The following is a description of a gene set: Any process that results in a change in state or activity of a cell or an organism (in terms of movement, secretion, enzyme production, gene expression, etc.) as a result of an abiotic (not derived from living organisms) stimulus. studied in species Mus musculus Mouse Gene Set: GOBP_RESPONSE_TO_ABIOTIC_STIMULUS, and this is the list of marker genes: Cetn1, Mir705, Sik1, Slc7a11, Ifi208, Triap1, Chek1, Prkcd, Ripor2, Trex1, Mir133a-1, Insrr, Ankrd23, Mir223, Best1, Wrn, Ada, Stx1a, Egfr, Slc29a1, Rock2 (NCBI Gene Id 77848), Fgf2, Chi3l1, Akt2, Cacna1e, Neurod2, Mir26a-2, Lonp1, Mir665, Mtpn (NCBI Gene Id 319218), Bhlhe40, Carlr, Kcnj3, Hsf3, Rnf34, Casp2, Ece1, Apobec1, Vegfc, Mfap4, Zfp36l1, Fndc1, Kat5, Atg7, Mir31, Gucy2f, Trpv4, Pkd1l3 (polycystic kidney disease 1 like 3), Rbx1-ps, Inip, Nedd4l, Agtr1a, Kras, Scn1a, H2ax, Ajuba, Hsd11b2, Pdcd6, Nfe2l1, Bcl3, Cers1, Acer1, Fzd4, Xrcc5, Rbm4, Adm, Nfatc4, Tsc22d2, Lrit1, Ddhd2, Tert, Gip, Pten, Stc2, Chrd (NCBI Gene Id 12667), Slc52a3, Trpm2, Egln2, Ptprq, Slc39a12, Opn1sw, Slc2a4, Hsbp1, Arrb2, Ucn3, Mir29b-2, Mir511, Ghrl, Nsmce3, Angpt4, Angpt2, Chrna5, Strbp, Ngb, Palm (NCBI Gene Id 18483), Cacnb4, Mir16-1, Usp1, Grin1, Il12a, Cat, Cryab, Lcn10, Col6a2, Nlrp3, Gpr151, Nos1, Rhno1, Smad4, Creb1 (NCBI Gene Id 98624), Polk, Itpr1, Asic2, Eif2b2, Kmo, Ang, Dram1, Igfbp2, Parp1, Mkks (McKusick-Kaufman syndrome), Star, Pold1, Kcnj8, Pld2, Mtor, Acaa2, Nfkbia, Epas1, Tmc1, Mdm2, Dnaja1, Xylt1, Eno1, Bag3, Aen, Hilpda, Tspo, Mir574, Il12b, Ccr2, Clcn2, Vhl, Meis2, Higd1a, Usp15, Rtn4, Ccng1, Chrna4, Scel, Asns, Eif4ebp1 (eukaryotic translation initiation factor 4E binding protein 1), Lrp2, Aqp5, Strc, Fam162a, Ihh, Pgk1, Ager, Loxl2, Hp1bp3, Pnp, Spidr, Rad23b, Ttn, Trh, Stk39, Ddah1, Mapk3, Fyn, Srf, Nucks1, Myod1, Vps13a, Sdhd (NCBI Gene Id 97524), Ddb1, Mir668, Tek, Adam2, Adam8, Cysltr1 (cysteinyl leukotriene receptor 1), Pde2a, mt-Co1, Kcnj11, Slco1b2, Grm8, Ddx3x, Bak1, Adam17, Cdc25a, Mapt, Sst, Mir711, Nek1, Ntsr1, Rdh13, Scx, Gucy1b2, Fcor, Txnip, Sod1, Capn2, Hspb6, Kdm4d, Hsp90aa1, Ddias, Large1, Rad51, Mir154, Sod3, Nop53 (NOP53 ribosome biogenesis factor), mt-Nd5, Tnks1bp1, Alas2 (aminolevulinic acid synthase 2, erythroid), P4hb, Nts, Atp1b1, Per2, Hk2, Nlk, Ephb1, Stra6, Tacr2, Grin2b, Mir301, Atp2b4, Gpr4, Krt5, Appl2, Disc1, Prl8a2, Pbk, Fzd3, Plin1, Mir15a, mt-Nd1, Mir148b, Ak4, Scrn3, Kcnma1, Ext1, Mlc1, Pik3ca, Pcsk1n, Tcim, Uts2, Fbxo4, Tac1, Id2, Nrxn2, mt-Atp6, Ercc6, Csrp3, Crb1, Ei24, Camk2d, Il3, Smad3, Tm9sf4, Irf1, Il1r1, Ifi214, B4galt2, Cdkn1b, Penk, Tuba1a, Gjb6, Krt14, Mc1r, Tifab (TRAF-interacting protein with forkhead-associated domain, family member B), P2ry1, Il18, Lrrn4, Map1b, Angptl4, Ankrd1, Rrh, Eif2s1, Lrit3, Cr1l, Mir222, Cngb1, Slc27a1, Pkd1l1, Slc12a6, Ltbr, Adora1, mt-Nd3, Prkdc, Brca1, Mirlet7b, Pkn1, Mir133b, Daxx, F11r, Ndufs2, Pde6c, Nrg1, Mme, Kcna1, Ppp1cb, Grb2, Tulp1, Cacna1c, Ifi206, Cd24a, Rhbdd1, Mdk, Serpinb6c, Rcvrn, Pdcd10, Map4k3, Ybx3, Aurkb, Gnb1, Hspa8, Tmbim6, Micu1, Clk2, Atp1a1, Tipin, Flt1, Tafa2, Umod, Rad9b (NCBI Gene Id 320366), Scn2a, Bbc3, Eif2b5, Rad51ap1, Pcare, Scn9a, Yy1, Mir1895, Mmp1b, Hras, Mapk10, Nf1, Rbm4b, Uimc1, Etv1, Htr2a, Foxo3, Ercc1, Tmem87a, Gucy1a2, Crtc1, Eya1, Cryaa, Ubqln1, Cxcl12, Babam2, Vcp, Mir30e, Ace, Foxb1, Gsn, Cyp2r1, Cd40, Dynlrb1, Ivl, Xrcc1, Map3k20, Mgarp, Gnat1, Ptgs2, Tacc3, Ercc8, Hus1, Tsc1, Col3a1, Brcc3dc, Atp1a3, Hmgcr, Chp1, Ric8a, Lrrc8d, Birc2, Wtip, Stat3, Cdkn2d, Rho, Slc25a27, Lrrc8e, Mirlet7e, Fbxl3, Rpe65, Cxcl2, Dclre1c, Pparg, Bnip3, Tlr3, Slitrk6, Agap3, Atp6v0a2 (ATPase, H+ transporting, lysosomal V0 subunit A2), Eif2b3, Anxa7, Tgfb1, Vegfa, Cacnb3 (calcium channel, voltage-dependent, beta 3 subunit), Lif, Higd1c, Shank3, Ccdc115, Ube4b, Mmp9, Dct, Ift20, Dhx36, Sost, Foxp2, Brca2, Npepps, Txn2, Sdf4, Efhd1, Mir376a, Trpa1 (transient receptor potential cation channel, subfamily A, member 1), Agtrap, Acadm, Gad2, Aqp3, Mir204, Dcdc2a, Bdkrb1, Wnt11, Tfec, Atoh7, Lrrc8c, Plekhn1, Abcc9, Ang4, Slu7, Slc1a1, Ticrr, Mstn, Pmp22, Ero1a, Pkdrej, Txn1 (thioredoxin 1), Cpeb1, Cry2, Mir199a-2, Endog, Itga2, Tlr7, Adss2, Mir30b, Reep6, Ube2b, Hspb2, Mir762, Comt, Kmt2a, Ifi203, Dnaja2, Nlgn3, Kdr, Gpsm2, Psip1, Scn11a, mt-Cytb, Col11a1, Gata6, Slc8a1, Rpl26, Mir7b, Ints7, Lpar1, Oxtr, Itgb6, Ap1s2, Xrcc4, Ddit4, Nedd4, Guca1a, Myc, Bmp6, Nhej1, Rab11fip5, Mir140, Mir483, Ptpn1, Ctnnb1, Pak1, Mir10a, Prkg2, Per3, Prl4a1, Rbx1, Mir9-2, Ptgis, Atp6v1a, Usp2, Eif2b4, Mir92b, Nppb, Myo6, Ercc2 (excision repair cross-complementing rodent repair deficiency, complementation group 2), Sirt1, Abcb1a (ATP-binding cassette, sub-family B member 1A), Ang2, Col6a1, mt-Co2, Mir1192, Gja3 (gap junction protein, alpha 3), Adrb1, Pola1, Ppp1r1b, Mir499, Nfkb1, Usf1, Aqp2, Drd3, App, Mir379, Zfp976, Relb, Htr7, Suv39h1, Acvr2a, Crnn, Uaca, Opn5, Acot11, Kcnq1, Tlr8, Xrra1, Grk1, Ckm, Rad54l, Rgcc, Hmox1, Tbl2, Hoxa1, Mir127, Ccnd1, Pclaf, Nr4a2, Mir132, Ttpa (NCBI Gene Id 50500), Sumo1, Vasn, Slc4a10, Kcnk9, Nr2f6, Ppid, Noc2l, Trp53bp1, Hnmt, Kcnd2, Gnb5, Brcc3, Tsc22d3, Blm, Fancg, Calca, Atxn3, Hspa2, Sox2, Ccna2, Chrna9, Ccdc66, Kcnj2, Pln, Ndrg4, Hpn, Mir207, Rela, Cntnap2, Atp6v0d1, Mief1, Polr2a, Cops9, Polh, Hnrnpd, Acot2, Atxn1, Ednra, Tnfrsf11a, Zbtb1, Pold3, Hikeshi, Mmp3, Map2k1, Rgs14, Th, Ucn, Chrna10, Slc8a3, Fabp1, Src (Rous sarcoma oncogene), Sipa1, Hyal1, Mir34a, Sox4, Rest, Mir199a-1, Kdm1a, Tsc2, Drgx, Bcl2l1, Casp9, Lck, Mir30d, Prmt2, Kcnq3, Mir194-2, Serpinb6a, Metrnl, Mir874, Opn1mw, Vac14, Grin2d, Mir3092, Xbp1, Tlr4, Rad23a, Ryr2, Lep, Sirt6, Ascl1 (NCBI Gene Id 17172), D7Ertd443e, Pgf, Nog, Fbxw7, Egln1, Rbbp7, Hyal3 (NCBI Gene Id 235600), Ang6, Thra, Trpv2 (transient receptor potential cation channel, subfamily V, member 2), Hsp90ab1, Rad21, Ifi209, Slc7a5, Hsp90b1, Sfrp1, Mmp1a, H2ac25, Casp1, Cbl, Mmp24, Vldlr, Ang5, Mbd2, Lrrc8a, Ep300, Serpine2, Htra2, Crebbp (CREB binding protein), Per1, Nrxn1, Myof, AU040320 (NCBI Gene Id 100317), Pml, Pdcl3, Kcnc2, Trp53i13, Wdr47, Arpp21, Ercc3, Cln3, Mt3, Mir100, Col1a1, Ifi213, Scnn1g, Slc12a2, Cdk2, Prph2, Ccl2, Rad18 (RAD18 E3 ubiquitin protein ligase), Limd1, Nppc, Nrf1 (nuclear respiratory factor 1), Gpr65, Akap12, Mir107, Kcnq2, Ccl7, Gba1, Slc4a11, Ywhae, Jup, Cav1, Arrb1, Calb1, Pck1, Myo15a, Zfp516, Aqp1, Ptprk, Dnajc3, Marveld3, Piezo2, Smpd1, Ddb2, Casr, P2rx2, Mir3473c, Kars1, Mir26a-1, Hif1a, Hyou1, Mndal, Ptprc, Tmc2, Lct, Tmem135, Mapk13, Scara5, Casq1, Aldh18a1, Rab3a, Usp28, Il1a, Cyp1a1, Chuk, Nox1 (NCBI Gene Id 278150), Letm1, Plau, Gpx1, Fmn2, Mir221, Mir300, Sirt4, Ndnf, Calr, Rgr, Syngap1, Hsf1, Pawr, Bmf (BCL2 modifying factor), Prickle2, Plod1, Itgb3, Clcn6 (NCBI Gene Id 26372), Itpr2, Eif2ak4, Agtr1b, Elane, Tmem199, Rps6kb1, Atp2b2, Mbd4, Tnf, Myocd, Mir142, Fbxl21, Inhba (inhibin beta-A), Capn3, Abl2, Chek2, Nfatc3, Oxsr1, Pcna, Rgs9, Nipbl, Bace1, Tmem150c (transmembrane protein 150C), F7 (NCBI Gene Id 14068), Fech, Nlrp1b, Agt, Dio3, Pick1, Myog, Fundc1, Mir365-1, Tgfb2, Pjvk, Grm6, Ercc4, Eif2ak3, Nfat5, Pou4f2, Sod2, Elk1, Chrna7, Hif3a, Lhfpl5, Grin2a, Dtl, Cldn3, Smpd2, Zmpste24, Rad54b, Tnfrsf1a, Tanc1, Cry1 (cryptochrome circadian regulator 1), Xrcc6, Mir9-1, Mir20b, Foxo1, Fosl2, Clock, Oprd1, Akt1, Lxn, Mst1, Hspd1, Pink1, Cbfa2t3, Slc38a2, Reg1, St8sia1, Plk3, Kcnk18, Rnf8, Fosb, Casp7, Igf1, Rgs9bp, Cds2, Hyal2, Abat, Cbs, Kcnc1, Thbs1, Fas, Vegfd, Nos2, Mir199b, Mir410, Ptprd (NCBI Gene Id 71786), Arnt2, Gpr68, Adam15, Mir133a-2, Bax, Prickle1, Irak1, Scnn1a, Cul4a, Cnn2, Sema5b, Fbxo32, Pnpla2, Mir691, Atm, Sema5a, Mir21a, Edn1, Swi5, Cav3 (caveolin 3), Mir434, Tcap, Mir451a, Rasa3, Nkx3-1, Pierce1, Atf2, Hvcn1, Tlk2, Hmgn1, Cybb, Mir125b-1, Pkd1l2, Phf24 (PHD finger protein 24), Lipe, Zfas1 (NCBI Gene Id 68949), Ppp1ca, Slc2a8, Bdkrb2, Lta, Cep250, Plat, Sts, Scn2b, Phb2 (prohibitin 2), Lncbate10, Ptafr, Pirt, Ado, Gnat2, Itgb1, Smc1a, Deaf1, Ankrd2, Tspyl5, Nscme3l, Eif2b1, Sun1, Htt, Saxo1, Cdk5 (cyclin dependent kinase 5), Grm1, Acadvl, Lrrc25, Ano3, Abhd12, Paxip1, Mrnip, Asic1, Map2k7, Notch1 (notch 1), Pianp, Rhob, Slc4a1, Piezo1, Brsk1, Pcp2, Pde8b, Clpb, Crhr1 (NCBI Gene Id 12921), Tmem120a, Prkaa1 (protein kinase, AMP-activated, alpha 1 catalytic subunit), Gpld1, Pygm, Pde1b, Neto1, Mill1, Xrcc2, Rac1, Mir208a, Arnt, Cfh, Slc6a4, Ube2a, Slc12a5, Cited2, Trp53, Rbp4, Ryr1, Serpinb6b, Prap1, Nfe2l2, Trem2, Map3k14, Mir365-2, Ndufs4, Mir101b, Eef2k, Dbh, Cck, Dmd, Tg, Nabp2, Polb, Fbp1, Ptch1, Pdk1, Cxcr4, Gngt1, Serpinf1, Ano1, Gata4, Ucp1, Sirt2, Mkx, Bnip3l, Map1lc3a, Mir327, Mir103-1, Gnat3, Ptger4, Vgf, Rab11b, Ect2, Ifi207 (interferon activated gene 207), Mta1, Lipa, Mir26b, Slc38a3, Dpm1, Brd1, Stac, Actr5, Wdr83, Parp2, Scnn1b, Gria1, Stc1, Opn4, Ptpn11, Fancd2 (Fanconi anemia, complementation group D2), Rom1, Abcg5, Trpv1, Wnk3, Drd1, Nlrp1a, Slc9a1, Gpi1, Gdf5, Tmem109, Xpa, Abcb1b, Mirlet7d, Akr1b1, Pdzd7, Il1b, Map7, Chchd2-ps (NCBI Gene Id 433806), Rad1, Usp53 (NCBI Gene Id 99526), Cdkn2a, D1Pas1 (DNA segment, Chr 1, Pasteur Institute 1), Scn7a, Ngfr, Hspa1a, Rbm3, Pmaip1, Ndrg1, Tank, Eno1b, Pde6d, Hpcal4, Mir9-3, Musk, Frmpd1, Brat1, Nsmf, Chrnb2, Acvrl1, Got1, Gfi1, Tjp1, Cpeb4, Grik2, Otop1 (otopetrin 1), Crip1, Pin1, Net1 (NCBI Gene Id 78563), Epha4, Timp1, Ercc5, Gpr88, Mir335, Prdm12, Atp8a2, Fos, Raf1, Mir491, Kcnk3, Prkaca (NCBI Gene Id 18747), Myd88, Mmp2, Mettl3, Pax2, Gpr52, Ppp1cc, Actb, Ninj1, Ckap5, Rnf4, Synpo, Tac4 (tachykinin 4), Hpca, Slc1a3, Map2k4, Eya3, Eng, Fignl1, Kcnk2, Hrh2, Serpinb6d, Ints3, Dnaja4 (NCBI Gene Id 80397), Atp1a2, Abcc8, Acta1, Bltp1, Gja1, Nps, Adgrv1, Arhgdia, Pin1rt1, Gucy1b1, Nr4a1, Lmna, Xpc, Dhx9, Pdlim1, Dnmt3a, Dnajb1, Irx6, Tacr1, Rora, Pkd2l2, Npm1, Tfrc, Brip1, Uvssa, Plac8, H2aj, Mknk1, mt-Nd4, Mir5621, Fosl1, Cyfip1, Bcl2, Drd5, Braf, Nabp1, Ireb2, Ttr, Pik3r1, Mir143, Scap (SREBF chaperone), Hspa1b (NCBI Gene Id 15511), Gja10, Ctns, Stk11, Rad9a, Adrb2, Sct, Krt8, Habp4, Kcne1, Bmp2, Tgfb3, Ppara, Abraxas1, D130043K22Rik, Msh2, Aipl1, Rcsd1, Mir137, Mir760, Gypa, Sox9, Rptor, Sde2, Bbs10, Trpm1, Adsl, Trp53inp1, Hspb1, Mtch2, Kit, Mcrip2, Slc2a1, Tsc22d4, Slc26a5, Cacna2d4, Gh, Oxt, Ciao3, Sgk1, Topbp1, Mir146, Rev1, Trpv3, Lyn, Il33, Cop1, Ptk2b, Rnf170, Mapk9, Cd14, Nos3, Cacna1f (calcium channel, voltage-dependent, alpha 1F subunit), Pcdh15, P2rx5, Twist1, Ruvbl2, Clcn7, Pdpk1, Atat1, Scn10a, Suv39h2, Hsbp1l1, Mir15b, Hmgcs2, Babam1 (BRISC and BRCA1 A complex member 1), Atp6ap1, Dpp4, Jun, Plec, Tnfsf14, Cidea, Slc24a4, Ccar2, Mir99a, Apaf1, Psph (phosphoserine phosphatase), Atf4, Adipoq, Mag, Pias1, Mcoln1, Mapk14, Ndp (NCBI Gene Id 236713), Mir155, Kcna5, Cdkn1a, Lgmn, Cygb, Tyr, Slc1a2, Vegfb, Wnk1, Bcl10, Tigar, Mir126a, Yap1, Mir150, Mlst8, Dnaja3, Ifi203-ps, Mir652, Cysltr2, Btg2, Pik3cb, Cpt1b, Cradd, Gucy1a1, Nol3 (nucleolar protein 3 (apoptosis repressor with CARD domain), NCBI Gene Id 78688), Pkd2, Casp3, Gap43, Bad, Bard1, Mir29b-1, Gsk3b, Asic3, Dnm1l, Zeb2, Mecp2, Cabp4, Cd38, Mir495, Col6a3, Dcun1d3, Clca1, Rpgr, Rag1, Nptn, Scfd1, Mir214, Egr1, Ogt, Mir146b, Egln3, Mir16-2, Guca1b, Mpo, Usp19, Eef1d, Ascl2, Tnc, Mapk11, Ciita, Ier5, N4bp1, Pdk3, Bmyc, Ucp2, Nox3, Abraxas2, Trim32, Gpr31b, Rfwd3, Pkd2l1, Tfam, Chchd2, Trpm8, Ucp3, Pam, Adra1b, Dag1, Car9, Commd1, Idua, Tmem161a (transmembrane protein 161A), Mir92-2, Serpinb6e, Sfrp2, Gclc, Thbd, Fgf1 (NCBI Gene Id 14164), Whrn, Drd2, Becn1, Nono, Arsa, Gna11, Ccnd2, Hrh1, P2rx7, Gadd45a, Cpeb2, Kcnk4, Atp6v1g1, Acadl, Kdm6a, Mmp14, Camk2g (NCBI Gene Id 218813), Mir106a, Aanat, Ddr2, Alkbh5, Poli, Mir29c, Lig4, Ino80, B3gat1, Gata3, Rpain, Osm, Rrm1, Adrb3, Trp53bp2, Rnf168, Slc25a23, Ptn (pleiotrophin), Ces1d, Fadd, Agrp, Aifm1, Arsb, Pde6b, Alad, Gtf2h5, Nqo1, Epo, Neurog1, Ogg1, Mirlet7g, Pycard, Snai2, Mir695, P2rx3, Mir497, Ppard, Cdh8, Lrp11, Mir17, Zzef1, Mapk8, Map3k4, Atr (NCBI Gene Id 382093), Abca7, Mb, Aldh3a1, Sprtn, Dysf, Mir10b, Gpr179, Rwdd3, Cpt1a, Rp1, Zranb3, Opn3, Hmox2, Ttc36, Kcnk1, Ntrk1, Tpr, Msh6, Cirbp, Ro60, Prkce, Trim63, Ctss, Chordc1, Mylk, Postn, Mir5128, Pkd1, Primpol, Avpr1a, Cul4b, Men1